The following is a description of a gene set: Human Gene Set: HP_ABNORMAL_URINARY_ELECTROLYTE_CONCENTRATION studied in species Homo sapiens An abnormality in the concentration of electrolytes in the urine. Abnormal urinary electrolyte concentration, and this is the list of marker genes: FKBP6, MUC1, PIGT, EHHADH, HRAS, MEN1, CYP24A1, LIMK1, CASR, SLC34A3, COA8, FAM20A, CLIP2, INSR, CLCNKB, KCNJ18, TNFRSF11B, SERPINA6, ATP1A1, BSND, STX1A (syntaxin 1A), CLDN19, METTL27, ALPL, CDKN2B, FCGR2A, GRHPR, SLC2A2, GNA11, AMMECR1, AVPR2, BICC1, CYP27B1, GTF2I, ALDOB, HLA-DRB1, VPS37D, CLDN16, ALG5, CDKN1C, GCM2, TMEM270, EIF4H, PTH1R, KCNJ16, NCF1, SLC12A1, ABCC6, INPPL1, TBL2, ADCY10, CYP11B2, CDKN1A, DNAJB11, ATP7B (NCBI Gene Id 540), DNAJC30, MLXIPL, HNF1B, CYP11B1, CLCN5, FXYD2 (NCBI Gene Id 486), SURF1, FGF23, MC2R, CDKN1B, TMEM67, MAGED2, CFTR, HSD3B2, GNAS, BUD23, ELN, MRAP (melanocortin 2 receptor accessory protein), CYP11A1, IFT122, BTNL2, OCRL, ATP6V0A4, KRAS, ALG9, STAR, SCNN1A, KCNJ5, GTF2IRD2 (NCBI Gene Id 84163), DLG5 (discs large MAGUK scaffold protein 5), NNT, SARS2, GABRA3, DMP1, DCDC2, RFC2, NR0B1, KCNJ1, KCNJ10, IFT140, BAZ1B, CLDN10, GTF2IRD1 (NCBI Gene Id 9569), MT-TN, CYP21A2, TGFB1, GATM, SEC61A1, CDC73, PKD2, SLC22A12, HNF4A, PHEX, CACNA1S (NCBI Gene Id 779), NDUFAF6, ENPP1, SLC2A9, HSD11B2, NHERF1, SLC34A1, PIK3C2A, NRAS, TXNRD2, CTNS, CLCNKA, SLC12A3, PKD1, CDKN2C, GANAB, AP2S1